Given this list of marker genes Gria4, Alpl, Adarb2, Arhgap15, Btbd10, Dnajc11, Tlx1, B3gnt9, Zbtb4, Pilra, Faap24, Cxcl16, Gdf5, Slc25a21, Bbs12, Smarcad1, Insyn2a (NCBI Gene Id 627214), Grm6, St3gal1, Ddias, Kynu, Cops2, Nipa2, Epha5, Zc2hc1c, Gli2, Cadps2, Pcdh9, Pbx1, Cnrip1, Olr1, Ttll7, Adarb1, Cd2bp2, Gng7, Set, Apbb2, Tmem183a, Mcrs1, Polr3h, Tmem127, Xpo7, Plscr4, Galnt10, Gpatch8, Zfp113, Xcr1, Ncan, Sipa1l1, Pik3r3, St8sia2, Gnai1, Mtcl2, Sumo2, Clstn1, Clxn, Fam219a, Cdc45, Samd5, Slc16a2, Tspan5, Magi3, Glce, Csnk2a1, Mios (NCBI Gene Id 97312), Sp9, Ubl3, Lipa, Nid1, I830077J02Rik (RIKEN cDNA I830077J02 gene), Prtg, Acvr2b, Scimp, Pars2, Cd276, Fam163a, Epc1, Rab11fip4, Aldh1a1, Dync1h1, Ehbp1, Sik3, Zfp758, Slc26a8, Trdn, Cldn23, Bcl7a, Tmed8 (NCBI Gene Id 76230), Pnkd, Unc5c, Tcf12, Rbm18, Zfand5, Phf21a, B4galt1 (UDP-Gal:betaGlcNAc beta 1,4- galactosyltransferase, polypeptide 1), Itga9, Ptp4a1, Myo18a, Fnbp4, Pax3, Frmd6, Tmem240, Adgrd1, Zfp120, Acss1, Hormad2, Utf1, 5031439G07Rik, Astl, Klk5, Tubb5, Scamp1, Ptchd4, Popdc2, Ctdp1, Ercc6l, Grk1, Spry2, Macrod2, Hspb6, Hs3st3b1, Agap1 (ArfGAP with GTPase domain, ankyrin repeat and PH domain 1), Fbxw7, Ripply3, Aak1, Rrm2b, Dsc2, Tox3, Dlx3, Colgalt2, here is a description of the gene set: Genes predicted to be targets of miRBase v22 microRNA mmu_miR_7094b_2_5p in miRDB v6.0 with MirTarget v4 prediction scores > 80 (high confidence targets). studied in species Mus musculus Mouse Gene Set: MIR_7094B_2_5P from publication Chen Y, Wang X (PMID 31504780)